Given this list of marker genes FUT4, FUT9, FUT3, FUT5, FUT6 (NCBI Gene Id 2528), here is a description of the gene set: Pathway Definition from KEGG: nLc4Cer -- FUT3/4/5/6/9 -> Lex Human Gene Set: KEGG_MEDICUS_REFERENCE_LEWIS_X_ANTIGEN_BIOSYNTHESIS Lewis x antigen biosynthesis. Pathway ID: N01672. Pathway type: Reference. Pathway class: nt06035 Blood group carbohydrate antigen biosynthesis. species: Homo sapiens